Given this list of marker genes MT4 (NCBI Gene Id 84560), NFX1, SULT4A1 (NCBI Gene Id 25830), KIAA0586, ERC1, SLC22A6, PAX7, TMEM11, ARL3, PIAS2, AQP7, MC2R, NCKIPSD, STK17A, TMEM94, CAMK2G, SLC13A2, CEP162, GPATCH8, MSH3, ATP6V0A2, SLC4A3, RBBP8, IL16, CD6, MSX1, NXPE3, ECE2, IL13, BRD1, PIGR (NCBI Gene Id 5284), TBC1D22A, GRIP2, TBX5, DOK1, BMP10, IVL (involucrin), PRSS16, PSMF1, CYP2E1, SMG1, NPFF, ZNF592, KLHL18, SLC5A2, BNIP1, SLC2A1, KRT2, UTRN (NCBI Gene Id 7402), ESR1, CHD9, HTR4, ETV3, ITPR2, MYC, ZNF133, NOS2, ADCY3, GNPAT (glyceronephosphate O-acyltransferase), RXRG, TAF2, ATRX, ADCYAP1 (NCBI Gene Id 116), COLQ, FUT6, ABO, FNTB, BARX2, CRHR1, KRT86, POLR2K, MYO9B, CLPX (caseinolytic mitochondrial matrix peptidase chaperone subunit X), DRC3, BRCA1, KRT33A, PVR, SCAMP1, MPP2, CYP11A1, IRF2, DGCR5, IKBKE, ZKSCAN3, LTBP4, DPT, P2RY10, RASSF1, EP400, TRIM24, CRYAA, UBE4B, SSTR5, MSL3, ABCB9, ZNF157, CEP135, NRTN, HOXD4, FRYL, FOSL1, FIG4, PIGB, MAGEA9, MC5R, ZNF134, GPR19, SLC16A5, ZBTB22, TFDP2, SLC30A3, C1orf216, FLT1, NTNG2, PRELID3A, SLC6A11, ELAVL2, MGA, SYT5, RPS6KB2, GJB5, DNAJC16, JRK, WT1, BCL2, CTRL, PRKACA, RUNX1, ZNF710, CFH, SULT2B1, SCAPER, PPP1R3D, CLOCK, TBX19, PCF11, NR1I2, PHF10, AFF2, LPGAT1, PSG1, DTNA, KAT8, PAX9, TACC2 (transforming acidic coiled-coil containing protein 2), SIX3, DAPK2, KRR1, ENTREP1, TNFRSF25, MLN (NCBI Gene Id 4295), KRT1, MFN1, CDK13, ITIH4, AQP5, IPCEF1, NF1, GLE1, PLEKHB1, COX6A2, CASP10, PAXIP1, PAX8, POU6F1, PIK3CB, GRIK5, SLC22A24, HTR7, ZNF500, TTI1, AMFR, here is a description of the gene set: Human Gene Set: MORF_ESR1 Neighborhood of ESR1 species: Homo sapiens Neighborhood of ESR1 estrogen receptor 1 in the MORF expression compendium